Given this list of marker genes FGFBP1, FGF7, FGF22, FGF1, FGFBP2, FGF10, FGF3, FGF2, FGFR2, FGFBP3, here is a description of the gene set: studied in species Homo sapiens FGFR2b ligand binding and activation Human Gene Set: REACTOME_FGFR2B_LIGAND_BINDING_AND_ACTIVATION